The following is a description of a gene set: species: Mus musculus MAPK1 (ERK2) activation Mouse Gene Set: REACTOME_MAPK1_ERK2_ACTIVATION, and this is the list of marker genes: Jak2, Map2k2, Il6st, Il6ra, Mapk1, Tyk2, Ptpn11 (NCBI Gene Id 72646), Il6